The following is a description of a gene set: Any process that modulates the frequency, rate or extent of 3'-UTR-mediated mRNA stabilization. studied in species Homo sapiens Human Gene Set: GOBP_REGULATION_OF_3_UTR_MEDIATED_MRNA_STABILIZATION, and this is the list of marker genes: ELAVL4 (NCBI Gene Id 1996), ARID5A, LARP4B, TENT4A, QKI, TENT4B, ZFP36, METTL16, RBM24